The following is a description of a gene set: Mouse Gene Set: GOMF_COBALAMIN_BINDING Binding to cobalamin (vitamin B12), a water-soluble vitamin characterized by possession of a corrin nucleus containing a cobalt atom. species: Mus musculus, and this is the list of marker genes: Mtr, Cblif (cobalamin binding intrinsic factor), Mmab, Cubn, Tcn2, Mmut, Mmachc, Lmbrd1, Cd320 (CD320 antigen)